Given this list of marker genes CCL5 (NCBI Gene Id 8147), STAT3, CCL3, CNIH4, JAK1, STAT1, CCL4, NES, here is a description of the gene set: species: Homo sapiens Binding to a CCR5 chemokine receptor. Human Gene Set: GOMF_CCR5_CHEMOKINE_RECEPTOR_BINDING